Given this list of marker genes Rdh16, Sult2a6 (sulfotransferase family 2A, dehydroepiandrosterone (DHEA)-preferring, member 6), Rdh16f2, Awat2, Cbr4, Sult1e1, Adh6b, Sult2a8, Gdpd3, Pnlip, Chka, Retsat, Dgkq, Dhrs7, Rdh11, Cyp11a1, Ednrb, Rpe65, Rdh7, Akr1c13, Bmp6, Ces2e, Adh6a, Hao1, Dab2, Akr1c18, Cyp1b1, Aldh1a3, Acp3, Aldh1b1, Rdh8, Rdh1, Clcn2, Sult2a4, Cyp1a2, Akr1a1, Gdpd1, Bco1, Ces1d, Rdh10, Wnt4 (wingless-type MMTV integration site family, member 4), Hsd17b6, Cyp1a1, Adh4, Abhd4, Sdr9c7, Rdh13, Plb1, Ces2a, Aldh3a2, Rdh9, Akr1c21, Bmp5, Adh7, Dkk3, Tpk1 (NCBI Gene Id 29807), Cyp11b1, Sult1b1, Akr1c6, Gde1, Lrat, Akr1c12, Rdh19, Cacna1h, Rdh14, Ces2c, Sult2a1, Adh1, Akr1c14, Sult2a3, Aldh1a1, Dhrs3, Rbp4, Dhrs4, Sdr16c5, Aldh1a7, Cyp11b2, Sult2a5, Park7, Dgat2, Akr1b1, Rbp1, Akr1c20, Kcnma1, Rest, Naaa, H6pd, Hsd11b2, Aldh2, Lipe, Rdh5, Pnpla2, Aldh3b2, Pecr, Scnn1b, Akr1cl, Adh5, Sult2a7, Ces1f, Bmp2, Akr1c19, Aldh1a2, Thtpa, Napepld, Aldh3b1, Ces1e, Sult2a2, Rdh12, Dgat1, here is a description of the gene set: Mouse Gene Set: GOBP_PRIMARY_ALCOHOL_METABOLIC_PROCESS species: Mus musculus The chemical reactions and pathways involving primary alcohols. A primary alcohol is any alcohol in which a hydroxy group, -OH, is attached to a saturated carbon atom which has either three hydrogen atoms attached to it or only one other carbon atom and two hydrogen atoms attached to it.